Given this list of marker genes RNASE2, PIK3C2B, TPM2, SMAGP, MLLT3, BCL7A, CFD, BAALC, GNAI1, SETBP1, SPON1, CHRDL1, PAWR, PPP1R16B, FLNB, NPDC1, FAM30A, SPRY1, SNED1, SORBS3, EEF1A2, RBPMS, IGHM, PRKD2, SPTBN1, AZU1, CRIM1, CD22, ARHGEF17, ADGRL1, MN1, F2RL1, C3AR1, here is a description of the gene set: species: Homo sapiens Top genes from cluster 10 of acute myeloid leukemia (AML) expression profile; 41% of the samples are FAB M1 subtype, 45% have up-regulated EVI1 expression; indicate poor survival. Human Gene Set: VALK_AML_CLUSTER_10 BACKGROUND: In patients with acute myeloid leukemia (AML) a combination of methods must be used to classify the disease, make therapeutic decisions, and determine the prognosis. However, this combined approach provides correct therapeutic and prognostic information in only 50 percent of cases. METHODS: We determined the gene-expression profiles in samples of peripheral blood or bone marrow from 285 patients with AML using Affymetrix U133A GeneChips containing approximately 13,000 unique genes or expression-signature tags. Data analyses were carried out with Omniviz, significance analysis of microarrays, and prediction analysis of microarrays software. Statistical analyses were performed to determine the prognostic significance of cases of AML with specific molecular signatures. RESULTS: Unsupervised cluster analyses identified 16 groups of patients with AML on the basis of molecular signatures. We identified the genes that defined these clusters and determined the minimal numbers of genes needed to identify prognostically important clusters with a high degree of accuracy. The clustering was driven by the presence of chromosomal lesions (e.g., t(8;21), t(15;17), and inv(16)), particular genetic mutations (CEBPA), and abnormal oncogene expression (EVI1). We identified several novel clusters, some consisting of specimens with normal karyotypes. A unique cluster with a distinctive gene-expression signature included cases of AML with a poor treatment outcome. CONCLUSIONS: Gene-expression profiling allows a comprehensive classification of AML that includes previously identified genetically defined subgroups and a novel cluster with an adverse prognosis. from publication Valk PJ, Verhaak RG, Beijen MA, Erpelinck CA, Barjesteh van Waalwijk van Doorn-Khosrovani S, Boer JM, Beverloo HB, Moorhouse MJ, van der Spek PJ, Löwenberg B, Delwel R (PMID 15084694)